The following is a description of a gene set: from publication Xie X, Lu J, Kulbokas EJ, Golub TR, Mootha V, Lindblad-Toh K, Lander ES, Kellis M (PMID 15735639) Comprehensive identification of all functional elements encoded in the human genome is a fundamental need in biomedical research. Here, we present a comparative analysis of the human, mouse, rat and dog genomes to create a systematic catalogue of common regulatory motifs in promoters and 3' untranslated regions (3' UTRs). The promoter analysis yields 174 candidate motifs, including most previously known transcription-factor binding sites and 105 new motifs. The 3'-UTR analysis yields 106 motifs likely to be involved in post-transcriptional regulation. Nearly one-half are associated with microRNAs (miRNAs), leading to the discovery of many new miRNA genes and their likely target genes. Our results suggest that previous estimates of the number of human miRNA genes were low, and that miRNAs regulate at least 20% of human genes. The overall results provide a systematic view of gene regulation in the human, which will be refined as additional mammalian genomes become available. Genes having at least one occurrence of the highly conserved motif M159 GGCKCATGS in the regions spanning 4 kb centered on their transcription starting sites. The motif does not match any known transcription factor binding site. Human Gene Set: GGCKCATGS_UNKNOWN studied in species Homo sapiens, and this is the list of marker genes: FEZF2, PAX2, DHX30, MAP3K11, RSF1, RANBP1, RPL7, SPTBN4, OVOL1 (NCBI Gene Id 5017), SOCS2, CCNI, RDH10, USF2, GRM3, CCND1 (NCBI Gene Id 893), KLK3, FUT8 (NCBI Gene Id 2530), KCNK10, TRMT2A, CENPO, HK2, UBAC2, CCDC171, NF1, HS6ST3, OVOL2, ESF1, NDUFS8, BLVRB, CORO6, ZBTB17, MORC3, VSNL1, BASP1, ZFAND3 (zinc finger AN1-type containing 3), SLC7A10 (solute carrier family 7 member 10), CXCR4, INTS7, CABP7, BFAR, HAND1, RUNX1T1, CIPC, GPATCH11, GON4L, GOLGA1, B9D2, RBBP8, PRPF39, SMAD7, ACIN1, RAB23, JAG1, ZMYM2, FXR2, AAMDC, SDHB, CLOCK, C14orf119, CCAR1, NDUFAF5, AMMECR1L, PTPN2, CELF4 (NCBI Gene Id 56853), JADE2, CBFB, SMAP2, NEUROD1